Given this list of marker genes ZMYM2, LAMB4, PICALM, PPP1CC, SEPTIN2, C2orf49, ARPP19, SEPTIN7, BTG2, NCKAP1, RMND5A, NT5C1B, ZXDA, PRKX, PJA2, CUL3, CBLB, RPS6KA1, PACRGL, ZC3H12C, NR3C1 (NCBI Gene Id 389335), CARF, CUX2, DCAF4L1, USB1 (NCBI Gene Id 79650), SLC37A3, NEUROD6, CAPZA1, ATOSA, ATP6V1C1, NARS2 (asparaginyl-tRNA synthetase 2, mitochondrial), ARPP21, ONECUT2, JARID2, DMRT1, NFYA, CLDN11, CALM2, BRD10 (bromodomain containing 10), ARB2A, ZDHHC21, PDK3, SPRY1, SNURF, USP12, EPN2, SNRNP70, MGAT4A, ZNF124 (NCBI Gene Id 7678), CDC14B, ABHD3, SNAP91, BACH2, ZNF606, PLXNA2, POLR1B, ARL1, FEM1C, SMAD1, GORAB, ECHDC1, NIPAL1 (NIPA like domain containing 1), ANKS1B, ACYP2, AASDH, ZNF404, PIGA, UTY (ubiquitously transcribed tetratricopeptide repeat containing, Y-linked), MAGI1, RND3, AFF3, COBL, ZNF648, ZIC5, ZNF805, ARHGAP42, SP3, PACRG, WNK1, TUBB2B, SNAP25, MAP4K4, KRTAP13-2, NEIL2, CLASP2, SMC1B, ZFR, ZNF706, HSPH1, NMT2, KMT5B, BMF, MGAT5, AP1G1, TUBB2A, TOLLIP, MEF2C, BNC2 (basonuclin zinc finger protein 2), IMMT, TMEM202, ASAP1, AKAP1, SEPHS1, CTDSPL2, NRAS, here is a description of the gene set: Genes predicted to be targets of miRBase v22 microRNA hsa-miR-4709-5p in miRDB v6.0 with MirTarget v4 prediction scores > 80 (high confidence targets). species: Homo sapiens Human Gene Set: MIR4709_5P from publication Chen Y, Wang X (PMID 31504780)